The following is a description of a gene set: Neighborhood of TTK TTK protein kinase in the GNF2 expression compendium Human Gene Set: GNF2_TTK Neighborhood of TTK species: Homo sapiens, and this is the list of marker genes: RFC4, TYMS, PCNA, CCT2, CENPF, ASPM, FOXM1, CCNA2, GINS2, TTK, DBF4, KIF11, RRM1, PLK4, SMC2, MCM4 (minichromosome maintenance complex component 4), RACGAP1, CDK1, KIF18B, HMMR, CDC20, ZWINT, CKS2, FEN1, GMNN, MCM2, PRC1, MELK, TPX2, NDC80, NUSAP1, KIF2C, CENPU, SMC4, BUB1B, TOP2A, CCNB2, FANCI, HJURP